The following is a description of a gene set: Genes up-regulated in CD4 T conv: control versus over-expression of IRF4 and FOXP3. Human Gene Set: GSE40274_CTRL_VS_FOXP3_AND_IRF4_TRANSDUCED_ACTIVATED_CD4_TCELL_UP from publication Fu W, Ergun A, Lu T, Hill JA, Haxhinasto S, Fassett MS, Gazit R, Adoro S, Glimcher L, Chan S, Kastner P, Rossi D, Collins JJ, Mathis D, Benoist C (PMID 22961053) species: Homo sapiens The transcription factor FoxP3 partakes dominantly in the specification and function of FoxP3+ CD4+ T regulatory cells (Tregs), but is neither strictly necessary nor sufficient to determine the characteristic Treg transcriptional signature. Computational network inference and experimental testing assessed the contribution of several other transcription factors (TFs). Enforced expression of Helios or Xbp1 elicited specific signatures, but Eos, Irf4, Satb1, Lef1 and Gata1 elicited exactly the same outcome, synergizing with FoxP3 to activate most of the Treg signature, including key TFs, and enhancing FoxP3 occupancy at its genomic targets. Conversely, the Treg signature was robust to inactivation of any single cofactor. A redundant genetic switch thus locks-in the Treg phenotype, a model which accounts for several aspects of Treg physiology, differentiation and stability., and this is the list of marker genes: SAMD3, DCSTAMP, HSPH1, SHANK1, HAPLN2, ABTB3, ELOVL5, PSMB9, TES, SNED1, CD84, TSPAN5, CCDC184, GSAP, TNFRSF17, IL2, PDGFB, RTN4RL2, BRINP2, NOP16, SYTL3, KLF12, HGSNAT, BCL11B, FARP1, RERG, DZIP1, CYB5D2, POLR1G, ADGRE1, REEP1, GPR174, ID2, GRAMD2B, SBDS, IL10 (NCBI Gene Id 3586), HSP90AA1, ITGB1, CFDP1, GVINP1, CDKL2, BDKRB1, ACTN2, PLCD1, PIM1, CISH, MXD1, IGSF1, SHE, ATXN1, CREB3L2, DENND5A, JAK2, LRRC63, RNF11, DCTPP1, IGF1, GPR135, SEC24D, CXCR6, NIBAN1, EBF4, PTF1A, CNPY1, BATF, RNF19B, PRKCQ, ATP10D, GPR62, SMPDL3A, GIMAP4, MORF4L2, IRGM, FBXO44, LIPG, CEP55, STEAP2, UQCRFS1, HOXA10, ALX1, SUMO1, PKIB, ST8SIA1, CAPRIN1, EEA1, FAM170A, GRM4, FAM32A, KCNA3, FGL2, HERC3, MYCL, SKIL, GCNT2, FAM47A, CASTOR1, BMP3, DNTTIP2, CORO2A, PLSCR1, CELSR1, BIRC3, APIP, NLRP10, CDH23, PRPF31, CHRND, ADH1A, ATP13A4 (NCBI Gene Id 84239), CD40, IL1RAP, ADAMTS14, CCL5, MYO1F, AR, FAS, DTX4, PNO1, DTHD1, TAX1BP3, ITGA9, TMEM154, RNF2, HACD4, DENR, RAB10 (RAB10, member RAS oncogene family), DMRTA1, KRTAP4-1, GRHL1, WHRN, CYP51A1, TTC39C, WNK1, IDI1, IL36G, DNAJB13, IL34, GPR162, TIMM17A, GBP2, CYP2S1 (NCBI Gene Id 29785), CD3G, SLAMF1, CNOT2, SEPTIN10, LRRC25, KREMEN2, PPM1H, IGF1R, GUCA1B, FPGT, NRG2, TLX1, B4GALNT4, KIF3B, KDM2B, IL12RB2 (NCBI Gene Id 3595), CYSLTR2, WDR1, CCDC120